The following is a description of a gene set: studied in species Homo sapiens A protein complex that interacts with the carboxy-terminal domain of the largest subunit of RNA polymerase II and plays an active role in transducing the signal from a transcription factor to the transcriptional machinery. The core mediator complex has a stimulatory effect on basal transcription, and contains most of the same subdomains as the larger form of mediator complex -- a head domain comprising proteins known in Saccharomyces as Srb2, -4, and -5, Med6, -8, and -11, and Rox3 proteins; a middle domain comprising Med1, -4, and -7, Nut1 and -2, Cse2, Rgr1, Soh1, and Srb7 proteins; and a tail consisting of Gal11p, Med2p, Pgd1p, and Sin4p -- but lacks the regulatory subcomplex comprising Ssn2, -3, and -8, and Srb8 proteins. Metazoan core mediator complexes have similar modular structures and include homologs of yeast Srb and Med proteins. Human Gene Set: GOCC_CORE_MEDIATOR_COMPLEX, and this is the list of marker genes: MED29, MED10 (NCBI Gene Id 84246), MED20, MED15, MED21, MED19, MED14, MED7, MED4, MED24, MED28, MED31, MED17, MED26, MED18, MED11, MED9, MED22, MED30 (mediator complex subunit 30), MED23, MED1, MED27, MED8, MED6, MED16, MED25